Given this list of marker genes Gba2, Kdsr, Sgms1, St3gal2, Sgpl1, St6galnac5, Neu3, B3galnt1, Fut2, Gm2a, Sphk2, B3gnt5, Smpd3, Sumf2, Asah1, St3gal3, Cers3, Cers5, B4galt5, Glb1l2, Aldh3b1, Sptssb, Cers2, Asah2 (N-acylsphingosine amidohydrolase 2), Arsg (NCBI Gene Id 74008), Ctsa, Fa2h, Ugt8a, Neu2, St8sia5, Hexb, Gla, Arsk, Glb1l, Galc, Acer2, Plpp3, Smpd2, Neu1, B4galt6, Acer1, Cers1, Sgms2, Enpp7, Cerk, Ormdl3, Glb1l3, Ormdl1, Arsj, Plpp1, Samd8, Degs1, Arsa, Sgpp1, Sts (steroid sulfatase), Mfsd2b, Hexa (hexosaminidase A), Ormdl2, Sptlc1, Arsb, Smpd4, A4galt, Gal3st1, Arsi, Sptlc2, Smpd1, Plpp2, Gba1, M6pr, Aldh3a2, Ugcg (UDP-glucose ceramide glucosyltransferase), B4galnt1, Sptssa, Neu4, Degs2 (NCBI Gene Id 70059), St6galnac6, St3gal5 (NCBI Gene Id 20454), Glb1, Sgpp2 (sphingosine-1-phosphate phosphatase 2), Cers6 (ceramide synthase 6), Sumf1, Spns2, Psap, Aldh3b2, Sptlc3, Abcc1, Cers4, Cyb5b (cytochrome b5 type B), Fut1, B3galt4, Acer3, Sphk1, here is a description of the gene set: Mouse Gene Set: REACTOME_SPHINGOLIPID_METABOLISM Sphingolipid metabolism species: Mus musculus